Given this list of marker genes PEX19, FIS1, PEX11B, DNM1L, ACOX1, SEC16B, MFF, PEX11A, OPA1, CRYZL2P-SEC16B, PEX11G, ACOT8, here is a description of the gene set: studied in species Homo sapiens Human Gene Set: GOBP_PEROXISOME_FISSION The division of a mature peroxisome within a cell to form two or more separate peroxisome compartments.